Given this list of marker genes ATF3, SERPINE1, TSBP1, RHOU, LRRC32, TBC1D30, SLC23A1, JUN, ADRA2B (adrenoceptor alpha 2B), SLC25A25, CEBPD, MIR145, SYNDIG1L, CTLA4, FBXL19, PEG10, BIRC3, NEURL3, KLF4, TNFAIP3, ARL1, NFKBIZ, P2RY14, RCAN1 (regulator of calcineurin 1), ERP27, JUNB, LIF, KCNE4, DUSP6, CCL2, HRK, BTG2 (NCBI Gene Id 7832), HSPA1A, PHLDA1, ZIC5, MYO1A, RBKS, CABYR, EDN1, PRDX6, SPRY4, PRDM11, ADM2, SMARCA1, FOSB, MT1A, PI15, SLC25A33, CD80, PTGER4, GEM, CIRBP, IER3, PLK2, ADAMTSL3, SPRY2, COQ10B, ZFP36, DDHD1, RGS2, ALOXE3, HAMP, IL6, GDF15, CXCL1, IL17C, GPR65, HSPH1, SGK1, AKAP12, SDC4, IMPACT, ASB4, DOK7, MIR449A, RHOB, RGS1, NR4A2, ARL4D, MAGEA4, PELO, DUSP2, GPR143, FGF23, SOX13, NR4A1 (NCBI Gene Id 93352), LUC7L2 (LUC7 like 2, pre-mRNA splicing factor), HUS1B, APOLD1, H3-3B, PLEKHB1, TMEM65, FBXW10, SNX18, NXPH2, PRDM1, MMP3, ANKRD17, DNAI7, KDM6B, NRG1, ISY1, RBM3, SPRY1, FOSL2, DUSP1, CCSER1, IL1A, MIR143, TRIB1, IER2, PMAIP1, VWC2, PLK3, MEGF8, RPS29, CCL7, CEBPB, BHLHE40, MIR30A, NFIL3, ADAMTS1, MT2A, CD93, TNFSF18, SYT5, HMGB1, TBX3, NR4A3, FOS, EGR1, CXCL2, LITAF, SEMA4C, ATP1B4, DUSP5, CYTIP, IL12B, ANAPC10, WASL, PTGS2, HBEGF, PIK3C2A, DUSP4, IL10, EGR2, ITPKC, SHISA3, AGBL2, CCRL2, MAFF, LCORL, CBX2, here is a description of the gene set: Genes up-regulated in peritoneal macrophages: poly(IC) versus Pam3Cys-Ser-(Lys)4. species: Homo sapiens Human Gene Set: GSE36891_POLYIC_TLR3_VS_PAM_TLR2_STIM_PERITONEAL_MACROPHAGE_UP We have identified more than genes that have upregulated expression in TLR3 activated (PMI-1,2), but have downregulated expression in TLR2 activated (PMP-1,2) macrophages, as compared to control cells (PMC-1,2) from publication de Freitas A, Banerjee S, Xie N, Cui H, Davis KI, Friggeri A, Fu M, Abraham E, Liu G (PMID 22573805)